The following is a description of a gene set: Nitric oxide (NO) produced by macrophages (MØs) is toxic to both host tissues and invading pathogens and its regulation is therefore essential to suppress host cytotoxicity. MØ arginase 1 (Arg1) inhibits NO production by competing with NO synthases for arginine, the common substrate of NO synthases and arginases. Two signal transduction pathways control Arg1 expression in MØs. First, a MyD88-dependent pathway induces Arg1 in intracellular infections, while a second Stat6-dependent pathway is required for Arg1 expression in alternativelyactivated MØs. We found that mycobacteria-infected MØs produce soluble factors that induce Arg1 in an autocrine-paracrine manner via Stat3. We identify these factors as IL-6, IL-10 and GCSF. We further establish that Arg1 expression is controlled by the MyD88-dependent production of IL-6, IL-10 and G-CSF rather than cell intrinsic MyD88 signaling to Arg1. Our data reveal the MyD88-dependent pathway of Arg1induction following BCG infection requires Stat3 activation and may result in the development of an immunosuppressive niche in granulomas due to the induced Arg1 production in surrounding uninfected MØs from publication Qualls JE, Neale G, Smith AM, Koo MS, DeFreitas AA, Zhang H, Kaplan G, Watowich SS, Murray PJ (PMID 20716764) Human Gene Set: GSE22935_UNSTIM_VS_24H_MBOVIS_BCG_STIM_MACROPHAGE_UP studied in species Homo sapiens Genes up-regulated in macrophages: untreated versus 24h after M. bovis BCG infection., and this is the list of marker genes: ALKBH5, CNTNAP2, CPLX1, CCDC134, FZD7, SLC35F6, CTSE, FABP3, CHST10, TREM2, AMOTL2, EPB41L4B, CAMKK1, SLC50A1, ZNF821, DYNC1I1, MEP1A, FNDC10, COQ8B, PNPLA2, RRH, FABP7, ALPK3, SAMSN1, SLC16A6 (NCBI Gene Id 9120), TRAF3IP2, TACSTD2, RAB22A, CPSF7, SNX22, FRAT2, ARG2, SPATA4, CLDN6, ABCB8, KRT2, RPTN, PLA2G10, HK2, ATP8A2, ADAM9, SMPDL3A, TLR5, WLS, RNF19B, GIMAP7, MTSS1, HEATR6, HDAC6, GRB2, SPINT2, UBE2E2, BAZ2A, E2F4, MVB12A, GPR182, PNPLA3, P2RY2, AFF1, MED21, YWHAZ, SH3BP2, HK1, SPICE1, GBP4, TMEM144, APOBEC3B, PEDS1, CDKN1A, TSC2, SH2D1B, BCL2L14, NUP188, IRF1, ANPEP, PDE1B, ACOT9, IL17RA, MGST3, CRISP2, TNFSF13B, CEMIP2, ZIC5, STEAP4, NABP2, TAX1BP1 (NCBI Gene Id 8887), SELENOV, SFRP1, GSTM2, ATP2B2, HNF4A, FES, DYNLRB1 (dynein light chain roadblock-type 1), PTGER4, OLIG1, RMDN3, IQCC, UBE2H, TFF1 (trefoil factor 1), SERPINF2, NAT2, ADAM2 (ADAM metallopeptidase domain 2), CDPF1, TMEM38B, CFAP298, OVGP1, PLSCR1, RGS9, UBE2Z, RTN4R, NUDT9, MYO10, KISS1R, ITGAX, CRADD, ERAP1, RRP7A, TJAP1, CYP4B1, GPD1, ECI2, SLC4A4, HEXB, C1S, CD3E, XRCC2, SCN3A, SEC61A2, LITAF, IRF2, GRINA, RAB8B, NCK1, MAP3K2, WNT9A, OPN3, RCVRN, MC5R, TMC4, DTD1, HEBP1, GFAP, ZCCHC8, EHMT2, NACC1, TMEM243, PIK3C2G, MAPRE2, PTGS2 (prostaglandin-endoperoxide synthase 2), PLEKHO2, KCNK10, CSF3R, HIBADH, DPP7, MSRB1 (NCBI Gene Id 51734), CLP1, HTR1A, UBL4B, PIP4K2A, HACD2, FKBP8, LRRK2, WBP1, COLEC12, HGS, VAPA, EPB41L4A, SGO1, TMEM116, DUSP8, PCBD1, SOX3, HIVEP3, FBXL14, ADAMTS10, SLIT1, UPK2, KAT2B, RGS17, FKTN, G6PC2, HIP1, EIF2D, CRTC3 (CREB regulated transcription coactivator 3), ZEB1 (zinc finger E-box binding homeobox 1), DPF2, UCKL1, HOXB4, NDUFA7, CXXC1, NSUN5, CD302, TSPAN8, MAN1B1, JUND, KIF5A, CISH, SH3BP4, SHBG, PTGES